The following is a description of a gene set: The formation of an area of close contact between a lymphocyte (T-, B-, or natural killer cell) and a target cell through the clustering of particular signaling and adhesion molecules and their associated membrane rafts on both the lymphocyte and target cell, which facilitates activation of the lymphocyte, transfer of membrane from the target cell to the lymphocyte, and in some situations killing of the target cell through release of secretory granules and/or death-pathway ligand-receptor interaction. Mouse Gene Set: GOBP_IMMUNOLOGICAL_SYNAPSE_FORMATION studied in species Mus musculus, and this is the list of marker genes: Cd6, Git1, Lgals3, Msn, Havcr2, Ccl19, Nedd9, Dock2, Ephb1, Clec2i, Cd2ap, Ccr7, Prf1, Nck2 (non-catalytic region of tyrosine kinase adaptor protein 2), Ccl21a, Dock8, Dlg1, Cd81